Given this list of marker genes SRPK1, POLQ, SP140, CKS2, ARHGAP19, KIF4A, CCNB2, STIL, HSD17B10, PNKP, CDC25C, CENPF, MPHOSPH9, H4C3, PKIA, MRPS16, CCR2, STK39, TTC31, KIF2C, NCAPG, CTPS1, SEPTIN6, TK1, PTPN22, GATA3, CDR2, PLK1, GMNN, SNRPD1, SYNGR3, CSF2, MRPL11, CD38, ITGAL (NCBI Gene Id 3683), CXCR3, CCNA2, GMPS, CAPN2, CTLA4, TRIP13, TDP1, VDR, CCR4, CEP43, TACC3, CCR3, MAD2L1, KIF11, PRC1, TPX2, ESPL1, SMC6, FECH, PPP1R16B, JPT1, MCM7, TSPAN5, ASPM, GRAMD1B, PCNA, SHMT1, FUT8, NEDD4, TPGS2, PMCH, UBE2C, MCCC2, CDK1, CHST7, CDC20, IDH2, PRIM1, NCAPH, MCM2 (minichromosome maintenance complex component 2), DTL, KIF15, ARID3B, CCNB1, LMNB2, TRIB1 (tribbles pseudokinase 1), PWP2, DTYMK, RAD54L, RFC4, SYT11, DEF6, CDT1, TPM4, RRM2, CD96, BLM, NDC80, SELPLG, MANEA (NCBI Gene Id 79694), PHGDH, KIF20A, INPP5B, ABTB2 (ankyrin repeat and BTB domain containing 2), TFDP1, CBLB, AURKA, SLC27A2, CCR8, MCM6, CDCA8, CKAP5, SLAMF1, SIRPG, CD2, STAU2, LRRN3, EGR1, OIP5, HMMR, FEN1, TNFRSF4, ZCCHC4, NHERF1, ITGA4, ZWINT, HNRNPUL1, STS (steroid sulfatase), LAG3, PPM1G, STMN1, RBBP8, RAD51, GZMA, MELK, DCLRE1A (NCBI Gene Id 9937), IL2RB, HJURP, CENPA (centromere protein A), GGH, RNF187, CEP55, FANCG, FIBP, PTTG1, CENPE, PXMP2, TIMELESS, RBKS, RACGAP1, IFT52, EZR, ICOS, FASTKD3, GINS3, FAF1, MCM4, HELLS, ATG4A (autophagy related 4A cysteine peptidase), MYB, CHST12, CENPM, FANCI, RFC3, SNAPC3, OLA1, RAD51AP1, POLA2, HMGB3, PMS2P5, DUSP4, P2RX5, CLDND1, CLIC5, THG1L, NCALD, IL32, NUDT1, CREB3L2, KNTC1, HACD1, RAB27A, PLK4, PIEZO1, SNHG17, VIPAS39, CD79B, RBMX2, NUSAP1, MYH10, FAM200C, GINS2, TUBA3C, ZBTB24, DCPS, BBS7, DLGAP5, CDC45, CLEC2D, CCNE1, NEIL3, CD58, HMGB2, GOLGB1 (golgin B1), KIF22, here is a description of the gene set: from publication Prots I, Skapenko A, Lipsky PE, Schulze-Koops H (PMID 21347372) studied in species Homo sapiens Human Gene Set: GSE24634_TEFF_VS_TCONV_DAY7_IN_CULTURE_UP CD25+ regulatory T cells develop in the thymus (nTregs), but may also be generated in the periphery upon stimulation of naive CD4 T cells under appropriate conditions (iTregs). The mechanisms that regulate the generation of peripheral iTregs are largely unknown. We used microarrays to gain insights into the molecular program of extrathymic Treg development. Genes up-regulated in comparison of untreated CD25+ T effector cells at day 7 versus untreated CD25- T cells at day 7.